Given this list of marker genes RPS6KB1, SLC27A5, SLC27A2, AKT1, SPX, AKT2 (AKT serine/threonine kinase 2), ACSL3, FABP3, SLC27A6, SLC27A4, ACSL5, CD36, ACSL1, SLC2A1 (solute carrier family 2 member 1), EPRS1, IRS2, THBS1, SLC27A1, here is a description of the gene set: The directed movement of a long-chain fatty acid from outside of a cell into a cell. This may occur via transport across the plasma membrane or via endocytosis. A long-chain fatty acid has an aliphatic tail containing 13 to 22 carbons. Human Gene Set: GOBP_LONG_CHAIN_FATTY_ACID_IMPORT_INTO_CELL species: Homo sapiens